The following is a description of a gene set: A process that contributes to the first meiotic division. The first meiotic division is the reductive division resulting in the separation of homologous chromosome pairs. Human Gene Set: GOBP_MEIOSIS_I_CELL_CYCLE_PROCESS species: Homo sapiens, and this is the list of marker genes: CENPX, HSPA2, PRDM9, TEX11, NDC80, SPDYA, MUS81, MEI1, SYCE2, MOV10L1, TERB1, EME1, KASH5, SHOC1, CDC25B, UBB, SPATA22, CKS2, MSH4, PDIK1L, TEX15, TERB2, SIRT7, FANCD2, SYCE1, BRCA2 (NCBI Gene Id 82716), MAEL, FOXJ3, KLHDC3, RAD54B, UBE2B, PTTG2, MEIOC (meiosis specific with coiled-coil domain), DMC1, BTBD18, AGO4, TERF1, MEIKIN (NCBI Gene Id 730865), MLH3, ZWINT, C14orf39, PKMYT1, C9orf78, MAPK15, KNL1, P3H4, RAD50, TOP6BL, ATM, HFM1, CCNE1, USP17L2, IHO1, M1AP, CENPC (NCBI Gene Id 1060), WEE2, EHMT2, PLK1, BCL2L11, RMI1, HORMAD1, RAD51D, SYCP1 (synaptonemal complex protein 1), C1orf146, RAD51AP1, ESPL1, STAG3, MSH5 (mutS homolog 5), SYCP3 (NCBI Gene Id 50511), DDX4, FMN2, BRIP1, FOXJ2, PSMD13, STK35, RPL10L, REC8, SYCP2, MRE11, RAD54L, CCNB1IP1, PSMC3IP, TRIM75, PSMA8, SLC2A8, MND1, TEX12, MEI4, RAD51B, CNTD1, RNF212, FANCM, CCNB2, AURKA (NCBI Gene Id 8465), TOP2B, SYCE1L, UBR2, MYBL1, CCNE2, BAG6, EME2 (NCBI Gene Id 390668), NDC1, PIWIL2, CDC25C, DNMT3L, SYCE3, SLX4, SUN1, CENPS, ZSCAN21, MSH6, RAD51C, RAD21, SPO11, ZCWPW1, CDC25A, MAJIN, ANKLE1, BRDT, PTTG3P, TOP2A, RNF212B, CCNA1, FBXO5, BRME1, CDC20, DMRT1, TRIP13, SLC25A31, HSF2BP, DMRTC2 (NCBI Gene Id 63946), PTTG1, REC114, ING2, MLH1, ERCC4, TEX19, MEIOB, RAD51, ANKRD31, TDRD9, MCMDC2